Given this list of marker genes NPAS2, KCNK1, METTL13, CELSR2, POGLUT3, ARFGEF1, STT3B, ZCCHC7, FBXO33, PTPN3, UGT3A1, NDST3, RPL17-C18orf32, RNF138, ZNF764 (zinc finger protein 764), NFAT5, HMMR, C1orf116, HERPUD2, CCDC172, SPIB, FUT8, NRXN1, DNAJC11, ASIC1, TCF20, KDELR2, MTMR3, TMEM230 (NCBI Gene Id 29058), COL25A1, GAS7, ATP8B1, INSR, PHLPP1, OGN, GPR160, TRIOBP, LYN, ITGB3, IRGQ, BAG4, PATE2, ABCC2, PCDHB7, GALNS, CLOCK, NUDT21, PLXDC1, NR1D2, AGTR1, GDPD1, RPS3A, C18orf32, CCN1, ZBTB20, OXSR1, LYVE1, CKMT2, B3GALT1, GYS1, GFOD2, ZNF655, UBE2D3, FOXA1, RNGTT, AGR3 (NCBI Gene Id 155465), COL12A1, GIPC3, NCBP2, SMIM10, MATR3, FAM228A, MARCHF6, MYOT, BEX3, BICD2, NEFL, N4BP3, COL5A3, LIPG (lipase G, endothelial type), STK40, UBE3C, EPHX4, MYNN, FAM222A, EIF4EBP2, PTPRT, here is a description of the gene set: from publication Chen Y, Wang X (PMID 31504780) Human Gene Set: MIR4330 species: Homo sapiens Genes predicted to be targets of miRBase v22 microRNA hsa-miR-4330 in miRDB v6.0 with MirTarget v4 prediction scores > 80 (high confidence targets).